The following is a description of a gene set: TRIF-mediated programmed cell death studied in species Mus musculus Mouse Gene Set: REACTOME_TRIF_MEDIATED_PROGRAMMED_CELL_DEATH, and this is the list of marker genes: Cd14, Tlr4 (NCBI Gene Id 21898, toll-like receptor 4), Ripk3, Ly96, Ticam2, Ripk1, Fadd, Casp8, Ticam1